Given this list of marker genes C8G, C6, C5, C9, C7, C8A, C8B, here is a description of the gene set: Human Gene Set: KEGG_MEDICUS_REFERENCE_COMMON_PATHWAY_OF_COMPLEMENT_CASCADE_MAC_FORMATION species: Homo sapiens Common pathway of complement cascade, MAC formation. Pathway ID: N01490. Pathway type: Reference. Pathway class: nt06513 Complement cascade. Pathway Definition from KEGG: C5 -- ((C4b+C2a+C3b),(C3b+Bb+C3b)) -> C5b -> (C5b+C6+C7+C8+C9)